The following is a description of a gene set: Mouse Gene Set: GOBP_L_ARGININE_BIOSYNTHETIC_PROCESS The chemical reactions and pathways resulting in the formation of arginine, 2-amino-5-(carbamimidamido)pentanoic acid. species: Mus musculus, and this is the list of marker genes: Ass1, Nags, Cln3, Asl, Otc